Given this list of marker genes PGM3, C1QA, C3 (NCBI Gene Id 12266), ZNFX1 (NCBI Gene Id 57169), DNASE2, SLC37A4, DGKE, LMNB2, SOX18, here is a description of the gene set: Membranoproliferative glomerulonephritis species: Homo sapiens A type of glomerulonephritis characterized by diffuse mesangial cell proliferation and the thickening of capillary walls due to subendothelial extension of the mesangium. The term membranoproliferative glomerulonephritis is often employed to denote a general pattern of glomerular injury seen in a variety of disease processes that share a common pathogenetic mechanism, rather than to describe a single disease entity Human Gene Set: HP_MEMBRANOPROLIFERATIVE_GLOMERULONEPHRITIS